The following is a description of a gene set: Muscle fibrillation Fine, rapid twitching of individual muscle fibers with little or no movement of the muscle as a whole as ascertained by electromyography (EMG). If a motor neuron or its axon is destroyed, the muscle fibers it innervates undergo denervation atrophy. This leads to hypersensitivity of individual muscle fibers to acetyl choline so that they may contract spontaneously. Isolated activity of individual muscle fibers is generally so fine it cannot be seen through the intact skin, although it can be recorded as a short-duration spike in the EMG. Human Gene Set: HP_MUSCLE_FIBRILLATION species: Homo sapiens, and this is the list of marker genes: UNC13A, RYR1, TWNK, HINT1, SCO2, SOD1, FUS, BIN1, PRX, IFRD1, TBK1, CFL2, TREM2, LGI3, PPARGC1A, HNRNPA1, ATXN2 (ataxin 2), MPZ, CCNF, SETX, UBA1, TBCD, GLT8D1, TAF15 (TATA-box binding protein associated factor 15), PRRT2, POLG, TTC19, OPTN, ATXN3, SLC25A21, EXOSC9, TFG, AIFM1 (apoptosis inducing factor mitochondria associated 1), PRPH, SYT2, MEGF10, CHCHD10, PMP22, EGR2, PON2, TRAK1, MATR3, SQSTM1, ATP11A, TARDBP, NEK1, SLC52A3, DNM2, DAO, MTMR14, ATXN10, GLE1, PFN1, CHMP2B, EXOSC3, NDUFS4, SMN2, DENND5A, PON1 (NCBI Gene Id 5444), TSPYL1, SMN1, TOE1, CACNA1A, NEFH, AGTPBP1, ADPRS, VRK1, ANG, SPTLC1, CFAP410, ANXA11, PRUNE1, SLC25A46, NOP56, DYSF, RMND1, HSPB1, SCN1A, MYF6, GARS1, SBF1, ATP1A2, KCNK9, ASAH1, EXOSC8, PON3, FXR1, ERBB4, TBC1D24, DCTN1, GYG1, VAPB, FIG4, VCP, VWA1, UBQLN2, SLC52A2 (NCBI Gene Id 79581), SH3TC2